The following is a description of a gene set: Human Gene Set: GOMF_DEOXYRIBONUCLEOTIDE_BINDING Binding to a deoxyribonucleotide, any compound consisting of a deoxyribonucleoside that is esterified with (ortho)phosphate or an oligophosphate at any hydroxyl group on the deoxyribose moiety. studied in species Homo sapiens, and this is the list of marker genes: TREX1, DCTPP1, HSP90AA1, SAMHD1, DUT